The following is a description of a gene set: Abnormal EKG Human Gene Set: HP_ABNORMAL_EKG Abnormal rhythm of the heart. studied in species Homo sapiens, and this is the list of marker genes: TECRL, CDKN1B, TBX5, CACNA1A, PSMD12, CDKN2C, KCNQ1, LZTR1, ACTC1, FLNC, SLC1A3, RANGRF, MYL2, ABCC9, IRX5, GJA5, TMEM43, KCND3, KCNE2, GAA, SLC12A3, SOS2, CALM1, TTR, NEU1, KCNA5, SCN5A, MTFMT, EMD, PTPN11, ALG10B, GNAS, KRAS, PRKAG2, TNNC1, SCN3B, KCNJ18 (NCBI Gene Id 100134444), SEMA3A, JUP, CDKN2B, MYL3, SAA1, TLL1, MYH7, CALM3 (NCBI Gene Id 808), GYG1, DSG2, GNB5, KCNE3, SCN1B, TNNT2, CACNB2, FXN, SVIL, BRF1, DOHH, SPRED2 (NCBI Gene Id 200734), CALM2, KCNJ5, DYSF, KCNJ8, GATA4, SOS1, KCNH2, STX16, CDC73, DNAJC19, NRAS, SCN4B, CACNA1C, CLCNKB, PHOX2B, MECP2 (NCBI Gene Id 8274), CACNA1D, HADH, MYH6, PKP2, BPTF, PLXND1, MRAS, RASA2, DBH, AKAP9, CITED2, GPC3, KCNE1, GATA6, SLMAP, LTBP2, ACADVL, KCNJ2, SLC6A8, POLG, TNNI3K, ANK2, HCN4, LAMP2, DSC3, SNTA1, LMNA, CAV3, GPC4, CBL, SCNN1A, CAVIN1, RRAS2, ALPK3, ATP1A2, FBN1, TANGO2, DCAF17, SLC4A3, GMPPB, NPPA, GNB2, ATP1A3, KCNE5, COL6A1, CDKN1A, TBX20, NOS1AP, GABRA3, TRDN, RYR1, RRAS, RAF1, MT-CYB, TRPM4, SRY, ADAMTS10, ADAMTS17, DPAGT1, SCN10A, SCN2B, RIT1, DMD, NKX2-5, CACNA2D1, MEN1, GPD1L, CACNA1S